The following is a description of a gene set: Mouse Gene Set: GOBP_NUCLEOSIDE_PHOSPHATE_BIOSYNTHETIC_PROCESS studied in species Mus musculus The chemical reactions and pathways resulting in the formation of a nucleoside phosphate., and this is the list of marker genes: Acly, Tyms, Adss1, mt-Nd5, Acss1, Nadk, Adcy3, Adcy8, Gfpt1, Ndufb4, Gmpr2, Hk1, Atp5po, Nmrk1, Adcy1, Prps1, Guca1b, Cda, Ndufb10, Atp5mg, Acot7, Shmt1, Mlycd, Gnpda1, Kars1, Haao, Atp5f1e, Slc52a3, Dnajc30, Ak9, mt-Nd1, Atp6-ps, Stat3, Ndufa8, Rd3, Dctd, Bckdk, Ndufb7 (NCBI Gene Id 98326), Dtymk, Pdhx, Aprt (adenine phosphoribosyl transferase), Ndufb11, Adora2b, Dhfr, Uxs1, Ndufs8, Ak6, Acat1, Pank3, Aldoa, Ppat, Nppc, Nanp, Ppcs, Ndufs6, Tbpl1, Oas1a, Gfus, Naprt, Pgm3, Rfk, Atp5f1a, Fpgt (fucose-1-phosphate guanylyltransferase), Prps2, Umps, Gfpt2, Mthfd1, Pid1, Ndufa12, Antkmt, Ndufs2, Atg5lrt, Mpc1, Pnp, Rrm2b, Nppa, Papss2, Rrm2, mt-Nd2, Ctps2, Atp5pf, Atp5me, Gne, Ppcdc, Oasl2, Npr2, Adcy5, Kmo, Pdk1, Mthfd2l, Ndufa13, Pgk1, Ndufv2, Mapk1 (NCBI Gene Id 98012), Entpd8, Dcakd, Nme4, Adss2, Sphk2, Uap1, Rrm1, Mpi, Slc35a1 (NCBI Gene Id 99967), Acaca, Ak1, Ndufb5, Tpk1, Nmnat3, Nos3, Fam3a, Nans, Ndufa9, Tmsb4x, Prpsap2, Ak7, Uap1l1, Trem2, Atp5mc3, Vcp, Adk, Gnpnat1, Slc25a51, Ido2, Hprt1 (NCBI Gene Id 97612), Ctps1, Ndufb1, Dut, Gmpr, Ndufc2, mt-Nd3, Letmd1, Ndufc1, Ndufb3, Ndufa11, Gcdh, Gart, Nmnat2, Ldhc, Elovl4, Mpc2, Slc25a13, Ampd1, Ndufb9, Nme5, Atpsckmt, Nudt2, Nampt, Uck1, Adcy4, Ndufs1, Adsl, Impdh2-ps, Atp5mc1, Acsl1, Cmpk1, Atp5pd, Pank1, Pdhb, Upp2, Coasy, Gmps, Nme7, Impdh2, Sdhd, mt-Nd4l, Pank4, Gmppa, Ak3, Acss2, Uprt (uracil phosphoribosyltransferase), Gucy1b1, Pank2, Map2k1, Slc2a1, Gucy2d, Adcy2, Mmaa, Ampd3, Pmm1 (phosphomannomutase 1), Sdha, Ak5, Acacb, Shmt2, Ndufa1, Atp5f1d, Pdk3, Atp6v1a, Atp5mc2, Ndufb6, Ndufs5, Cmas, Ppara, Uqcc3, mt-Atp8, Guk1, Pdha2, Pth2, Dip2a, Pmm2, Prps1l3, Dlat, Kynu, Slc25a12, Ndufa6 (NADH:ubiquinone oxidoreductase subunit A6), Atp5if1, Dguok, Uckl1, Acsl4, Uck2, Elovl5, Atic, Amdhd2, Upp1, Cmpk2, Dhodh, Nme3, Mmut, Ak2, Dmac2l, Nadk2, Adcy7, Elovl3, Snca, Gucy1a1, Tk2, mt-Atp6, Tgfb1, Qprt, Prkn, Adcy10, Fcsk, Ndufab1, Gmds, Ldhd, Flad1, Ugp2, Ndufa10, Elovl1, Hnf1a, Slc25a16, Pfas, Elovl6, Il4, Acsl6, Slc35c1, Nppb, Nme6 (NCBI Gene Id 56803), Guca1a, Ndufv1, Eno1, Cad, Cox11, Ak8, Dld, Adcy6, Bcl2l1, Prps1l1, Slc25a42, Paics, Gnpda2, Myc (NCBI Gene Id 17869), Nadsyn1, Ndufs7, Ndufa2, Ido1 (indoleamine 2,3-dioxygenase 1), Ada, Acsl5, Lipa, Nme1, Stoml2, Atp5pb, Tk1, Slc4a7, Eno1b, Gucy2g, Nmrk2, Atp5mf, Fuom, Aspdh, Gucy2c, Atp5f1b, Npr1, Vdac1, Gmppb, Prpsap1, G6pdx, Impdh1, Ugdh, Parp1, Entpd1, Nmnat1, Dck, Ndufa7, Elovl7, Gars1, Ndufa5, Adcy9, Pdk2, Sdhc, Idh2, Papss1, Pdk4, mt-Nd4, Ndufs3, Afmid, Ndufs4 (NADH:ubiquinone oxidoreductase core subunit S4), Slc52a2, Ndufb8, Ak4, Gucy2f, Sdhb, Gucy2e, Ndufv3, Pdha1, Ampd2, Ndufb2, Pnp2, Nme2, Atp5f1c, Ndufa3, mt-Nd6